Given this list of marker genes MIR17, MIR27B, MIR143, MIR20A, HRG (NCBI Gene Id 3273), TMBIM1, here is a description of the gene set: Any process that activates or increases the frequency, rate or extent of blood vessel remodeling. species: Homo sapiens Human Gene Set: GOBP_POSITIVE_REGULATION_OF_BLOOD_VESSEL_REMODELING